Given this list of marker genes PB1, NS, PB2, HA, M, NP, PA, NA, here is a description of the gene set: species: Homo sapiens Reactome Pathway: Fusion and Uncoating of the Influenza Virion Uncoating of viral particles takes place in the host cell endosome. Acidification of the endosome promotes fusion of the viral and endosomal membranes, causing a structural change in the viral hemagglutinin (HA) and freeing the fusion peptide of its HA2 subunit to interact with the endosome membrane. The concerted structural change of several HA molecules opens up a pore through which the viral RNP passes into the cytosol of the cell. The precise timing and the location of uncoating (early vs. late endosomes) depends on the pH-mediated transition of the specific HA molecule involved. The virus-associated M2 ion channel protein allows the influx of H+ ions into the virion, which disrupts protein-protein interactions, resulting in the release of RNP free of the viral M1 matrix protein. Thus the HA mediated fusion of the viral membrane with the endosomal membrane and the M2-mediated release of the RNP results in the release of the RNP complex into the cytosol. Amantadine and rimantadine have been shown to block the ion channel activity of the M2 protein and thus interfere with uncoating. part of: Influenza Infection